Given this list of marker genes PCGF2, GLI2, NUP98, SOX10, FOXO1, MED1, KAT8, MECP2, SIRT1 (sirtuin 1), CHD7, ERCC3, TRIM28, PRDM1, EZH2, FOS, HNF1B, NRL, ERCC1, ATF2, L3MBTL2 (L3MBTL histone methyl-lysine binding protein 2), STAT1, RBL2, RBL1, KDM1A, ZNF609, EHMT2, GADD45A, KLF4, ZC3H4, WDR13, PCGF1, GTF2F1, POU4F2, SUZ12, NIPBL, ERCC4, DNMT1, DHX9, TP63, SMAD3, GTF2B, ZNF683, HDAC2, POLR2A, BMI1, ZNF304, FOSL1, FOXC1, TAF10, PDX1, MACROH2A1, SETDB1, FOXO4, NFE2L1, ATF4, NR3C1, HSF1, E2F4, ZNF750, HNRNPU, ISL1, TP53, IKZF3, TCF7L2, DDX5, FOXC2, IRF3, NDN, PRDM15, MYOD1, EGR1, HDAC1, here is a description of the gene set: Human Gene Set: GOMF_PROMOTER_SPECIFIC_CHROMATIN_BINDING studied in species Homo sapiens Binding to a section of chromatin that is associated with gene promoter sequences of DNA.